The following is a description of a gene set: Any cellular process that results in the specification, formation or maintenance of polarized cytoskeletal structures. studied in species Homo sapiens Human Gene Set: GOBP_ESTABLISHMENT_OR_MAINTENANCE_OF_CYTOSKELETON_POLARITY, and this is the list of marker genes: CAMSAP3, NCKAP1, AQP1, ARHGAP35, LMNA, KIF2C, PDLIM1, CKAP5